The following is a description of a gene set: Pathway Definition from KEGG: E7 -> (RB1,RBL1,RBL2) // E2F HPV E7 to cell cycle G1/S. Pathway ID: N00361. Pathway type: Pathogen. Pathway class: nt06166 Human papillomavirus (HPV). studied in species Homo sapiens Human Gene Set: KEGG_MEDICUS_PATHOGEN_HPV_E7_TO_CELL_CYCLE_G1_S, and this is the list of marker genes: E2F3, E2F1, E2F2, RB1, RBL1, RBL2